Given this list of marker genes Sln, Jph1, Hsp90b1, Mtmr12, Tmem38a (NCBI Gene Id 74166), Fkbp1a, Thbs4, Itpr2, Camk2d, Cacna2d1, Mrln, Akap6, Tmem109, Rtn2, Car4, Strit1, Art1, Nos1ap, Col6a1, Cacna1s, Klhl41, Calr, Agl, Nos1, Irag1, Slc30a7, Zfas1, Hrc, Stim1, Pln, Nox4 (NCBI Gene Id 50490), Ank3, Oprm1, Syne2, Srl, Trdn, Pygm, Thbs1, Casq1, Camk2b, Ccdc78, Dhrs7c, Sgcd, Fkbp1b, Itpr1, Hk2, Akap7 (NCBI Gene Id 54213), Nol3, Ank1, Jsrp1, Asph (NCBI Gene Id 97379), Hax1, Pomt1, Ryr1, Cacnb1, H6pd, Atp2a2, Ryr2, Gstm7, Cherp, S100a1, Ryr3, Sri, Itpr3, Slc2a4, Oprk1, P3h2, Cmya5, Reep5, Atp2a1, Xdh, Casq2, Akt2, Manf, Jph2, Rasd1, Atp2a3, Camk2g, Fsd2, Calu, Dmpk, Sar1a, here is a description of the gene set: A fine reticular network of membrane-limited elements that pervades the sarcoplasm of a muscle cell; continuous over large portions of the cell and with the nuclear envelope; that part of the endoplasmic reticulum specialized for calcium release, uptake and storage. studied in species Mus musculus Mouse Gene Set: GOCC_SARCOPLASMIC_RETICULUM